The following is a description of a gene set: from publication Chen Y, Wang X (PMID 31504780) Mouse Gene Set: MIR_7015_3P species: Mus musculus Genes predicted to be targets of miRBase v22 microRNA mmu_miR_7015_3p in miRDB v6.0 with MirTarget v4 prediction scores > 80 (high confidence targets)., and this is the list of marker genes: Fbxl17, Maoa, Rragd, Golm1, Fktn, Ctla2a, Lrrfip2, Wdr33, Dnajc27, Xrcc2, Cxcr2, Rap1gds1, Pgm1, Alcam, Mkx, Dph5, Zkscan1, Htr2c, Foxi1, Pramel13 (NCBI Gene Id 97182), Hmgcs1, Cops7b, Lcmt2, Aak1, Slc25a36, Zwint, Steap2, Dcc, Eif5, Nckap5, Errfi1, Rp1, Has2, Kcns3, Gpcpd1, Psg19, Spred2, Zer1, Abl2, Aktip, Ier3ip1, Slc39a2, Fam149b, Lrp11, 1810065E05Rik, Nr3c1, Ammecr1l, Tril, Frmd5, Meltf, Ifnar1, Alkal2, Arhgap17, Aif1l, Acsm5, Ubxn7, Gja8, Sec22b, Nfatc4, Ppp1r1c, Retreg3, Ermard, Glb1l2, Slc9b2, Fam117b, Krtap9-22, Sp3 (trans-acting transcription factor 3), Ccdc25, Sowaha, 5730507C01Rik, Rgp1, Cpxm2, Sertad2, Cd8a, Ccdc59, Sval1, Pi15 (NCBI Gene Id 94227), Gpr107, Rnf152, Vps33b, Gad1, Ino80, Amotl1, Dnm1, Usp13, Ccdc82, Prickle2, Gm266 (NCBI Gene Id 212539), Trib1, Bnip2, Dnajc16 (DnaJ heat shock protein family (Hsp40) member C16), Zfp300, Nlrp4e, Gja1, Chl1, Tent5a, Acvr1b, BC051665, Pggt1b, Cemip2, Zfp488, Adsl, Fzd3